The following is a description of a gene set: The coronavirus virion consists of structural proteins, namely spike (S), envelope (E), membrane (M), nucleocapsid (N) and, for some betacoronaviruses, haemagglutinin-esterase. The positive-sense, single-stranded RNA genome (+ssRNA) is encapsidated by N, whereas M and E ensure its incorporation in the viral particle during the assembly process. S trimers protrude from the host-derived viral envelope and provide specificity for cellular entry receptors. SARS-CoV-2 particles bind to angiotensin-converting enzyme 2 (ACE2) cellular receptors and together with host factors (such as the cell surface serine protease TMPRSS2), promote viral uptake and fusion at the cellular or endosomal membrane. Following entry, the release and uncoating of the incoming genomic RNA subject it to the immediate translation of two large open reading frames, ORF1a and ORF1b. ORF1a and ORF1b encode 1516 non-structural proteins (nsp), of which 15 compose the viral replication and transcription complex (RTC) that includes, amongst others, RNA-processing and RNA-modifying enzymes and an RNA proofreading function necessary for maintaining the integrity of the >30kb coronavirus genome. ORFs that encode structural proteins and interspersed ORFs that encode accessory proteins are transcribed from the 3' one-third of the genome to form a nested set of subgenomic mRNAs (sg mRNAs). The resulting polyproteins pp1a and pp1ab are co-translationally and post-translationally processed into the individual non-structural proteins (nsps) that form the viral replication and transcription complex. Concordant with the expression of nsps, the biogenesis of viral replication organelles consisting of characteristic perinuclear double-membrane vesicles (DMVs), convoluted membranes (CMs) and small open double-membrane spherules (DMSs) create a protective microenvironment for viral genomic RNA replication and transcription of subgenomic mRNAs comprising the characteristic nested set of coronavirus mRNAs. Translated structural proteins translocate into endoplasmic reticulum (ER) membranes and transit through the ER-to-Golgi intermediate compartment (ERGIC), where interaction with N-encapsidated, newly produced genomic RNA results in budding into the lumen of secretory vesicular compartments. Finally, virions are secreted from the infected cell by exocytosis. A successful intracellular coronavirus life cycle invariably relies on critical molecular interactions with host proteins that are repurposed to support the requirements of the virus. This includes host factors required for virus entry (such as the entry receptor and host cell proteases), factors required for viral RNA synthesis and virus assembly (such as ER and Golgi components and associated vesicular trafficking pathways) and factors required for the translation of viral mRNAs (such as critical translational initiation factors) Reactome Pathway: Late SARS-CoV-2 Infection Events species: Homo sapiens part of: SARS-CoV-2 Infection, and this is the list of marker genes: SRPK2, MGAT4B (NCBI Gene Id 11282), PARP10, ZDHHC3, SUMO1, 6, ANO5, RPN2 (ribophorin II), ANO6, MGAT2, ZDHHC5, RPN1, RPS27A, CSNK1A1, ANO10, UBA52, ANO7, ST3GAL3, GANAB, ANO4, ANO2, ZDHHC2, ZDHHC11 (zinc finger DHHC-type containing 11), UBC, DDOST, SRPK1, 3a, ST3GAL2, PARP9, ST6GALNAC3, ZDHHC8, CANX, MAN1B1, GALNT1, EDEM2, M, MAN2A1, MGAT4A, MAGT1, DAD1, UBB, PARP14, ZDHHC9, PARP8, FUT8, PARP16, PARP6, UBE2I, ANO9, ST6GALNAC4, GSK3A, MGAT4C, 9b, GOLGA7, E, ST3GAL4, N, ST6GAL1, S, ANO1, PRMT1, ANO3, ACE2, MGAT1, 8, STT3A, MOGS, PARP4, TUSC3, OST4, ST6GALNAC2, ANO8, STT3B, PRKCSH (PRKCSH beta subunit of glucosidase II), TMEM258, GSK3B, MGAT5, TMPRSS2, OSTC, SARS coronavirus, complete genome, 7a, ST3GAL1, FURIN, ZDHHC20